Given this list of marker genes WNT5A, METTL17, SYNJ2 (NCBI Gene Id 8871), NUDT5, EBF2, FAM168B, TMX4, RAN, MRPS14, MIR516B1, CLEC5A, TPM3, BCAT2, RBSN, PRKY, SRPRB, ATP6V1B2, GPR68, PANK2, EIF4E2, PIP4K2B, GPR132, ITGA11, CLEC10A, CAMK1, ADAM12, PPIH, PARM1, PRMT7, ETS1, ISOC2, PSMC1, BLNK, ISYNA1, IL16 (interleukin 16), MCOLN2, JAG1, SFMBT1, ZNF502, ISY1, CLEC1A, EXT1, OR5B2, EIF2B5, MANF, TNFSF8, LRRC8B, SNORD116-18, TNC (NCBI Gene Id 3371), CD1B, RALB, REEP1, PIP5K1A, NDUFA6, AKAP12, SLC16A1, CD226, TBC1D1, MRPL4, TRAP1, MCM3, SCN9A, ATP5MK, ELP3, RBM11, MRFAP1, NOL9, PTPRJ, PIK3R3, ABCC10, TPRG1, COA4, CCDC34, ARF4, RAB30, MAGOHB, DDX39B, CHCHD7, NUP88, IL21, NET1, SHQ1, SERPINB1, NDUFS1, ADORA3, ZNF491, NDUFV2, HEXIM1, OSGEP, XRCC6, COA6, CLECL1P, RAB35, SYNE1 (NCBI Gene Id 85448), BET1, PDIA6, RUVBL1, ABI3, TSPAN7, ALDH1B1, NUP93 (nucleoporin 93), CD101, DCUN1D5, GRB2, NRDE2, TXLNB, MATCAP1, HSPA5, CHAF1A, ARHGAP22, SHC3, CIR1, PPM1F, AIFM1, PTGER4, ATP8B4 (ATPase phospholipid transporting 8B4 (putative)), RAPH1, MAGEB16, SHCBP1, PSMA1, CIRBP, MTHFD1, GIMAP8, MFSD14B, SLC9A9, LCAL1, UMPS, ANXA2R-OT1, UBAP2L (ubiquitin associated protein 2 like), SLC41A2, GART, HCCS, L3MBTL2, RNF4, ANKRD18A, DCAF4L1, HDLBP, CTPS1, PSMC5, MTCL1, SLC25A15, SRSF2, LSM1 (LSM1 homolog, mRNA degradation associated), TRMU, NSUN2, RAB31, INPP4A, FAM120C, CFAP251, CYREN, KPNA2, UQCC1, CCNY, MRPL30, PARP1, FGF10, CD1E, NLRP3, DZIP1L, ZDHHC13, ASZ1, RASSF2, GNL3L, TTK, PCDHB2 (protocadherin beta 2), MTCH2, RPP14, TIFA, ICAM1, FUT8, C1QBP, CD93, GBP5, CCND1, PLEKHB2, PRPF4, ENO1, ATP5F1C, LAPTM4B, SLC11A2, SIGLEC5, ATF5, DPYSL2, IL1R2 (NCBI Gene Id 7850), VCAM1, CD84, STS, TATDN2, CRIPTO, NUDT3, TRAF3IP3, AK2, CLDN6, HAUS1, NIPA2, LANCL2, CD1A, PMFBP1, CLDN1, here is a description of the gene set: from publication Rivollier A, He J, Kole A, Valatas V, Kelsall BL (PMID 22231304) Dendritic cells (DCs) and macrophages (MPs) are important for immunological homeostasis in the colon. We found that F4/80hi CX3CR1hi (CD11b+CD103-) cells account for 80% of mouse colonic lamina propria (cLP) MHC-IIhi cells. Both CD11c+ and CD11c- cells within this population were identified as MPs based on multiple criteria, including a MP transcriptome revealed by microarray analysis. These MPs constitutively released high levels of IL-10 at least partially in response to the microbiota via an MyD88-independent mechanism. In contrast, cells expressing low to intermediate levels of F4/80 and CX3CR1 were identified as DCs, based on phenotypic and functional analysis and comprise three separate CD11chi cell populations: CD103+CX3CR1-CD11b- DCs, CD103+CX3CR1-CD11b+ DCs and CD103-CX3CR1intCD11b+ DCs. In non-inflammatory conditions, Ly6Chi monocytes differentiated primarily into CD11c+, but not CD11c- MPs. In contrast, during colitis, Ly6Chi monocytes massively invaded the colon and differentiated into pro-inflammatory CD103-CX3CR1intCD11b+ DCs, which produced high levels of IL-12, IL-23, iNOS and TNF. These findings demonstrate the dual capacity of Ly6Chi blood monocytes to differentiate into either regulatory MPs or inflammatory DCs in the colon, and that the balance of these immunologically antagonistic cell types is dictated by microenvironmental conditions. species: Homo sapiens Human Gene Set: GSE27859_MACROPHAGE_VS_CD11C_INT_F480_INT_DC_DN Genes down-regulated in macrophages versus dendritic cells sorted as ITGAX int and EMR1 int.